The following is a description of a gene set: species: Homo sapiens Genes down-regulated in unstimulated macrophages: IL10 knockout versus NFKB1 knockout. Human Gene Set: GSE19941_IL10_KO_VS_IL10_KO_AND_NFKBP50_KO_UNSTIM_MACROPHAGE_DN Bone marrow-derived macrophages were produced from mice lacking IL-10 alone (IL10-def) or mice lacking both IL-10 and the p50/p105 subunit of NF-kB (p50/IL10), and left unstimulated, stimulated with LPS (1 ng/ml) or stimulated with LPS and IL-10 (0.3 ng/ml). from publication Yang HT, Wang Y, Zhao X, Demissie E, Papoutsopoulou S, Mambole A, O'Garra A, Tomczak MF, Erdman SE, Fox JG, Ley SC, Horwitz BH (PMID 21217011), and this is the list of marker genes: MAGED1, SARAF, TMEM176B, ERMN, EPHA2, ZNF451, ABCB10, CUBN, PTGFR, MED13L, EMP1 (epithelial membrane protein 1), SLCO2A1, PTPN3, CCNB3, HOXD10, WDFY4, DLEU7, IFFO2, FBXO6, EBF1, PGAM1, PIK3R5, PI4K2A, IL20RA, IGSF11, ADM, TSPAN13, SKIL, MTSS1, VPS39, ZDHHC18, PALS1, DNAAF4, TLE2, TMEM104, GKAP1, EOLA1, DCC, PLAC8, PLAUR, GAD1, KIF1A, N4BP1, IRAG1, GPR65 (G protein-coupled receptor 65), CRTC3, VWA5B2 (von Willebrand factor A domain containing 5B2), WWP1, GLI3, CYFIP2, ASPN, AKTIP, ATG4C, TENT2, LAMP2, PCED1B, AQP9, GOLGA4, TCP11L2, GLIS2, RORA, MCTP2, PIK3R1, NLRP3, DNAJC10, GOLM1, GPR15, MFSD2A, BCL2L2, MAP3K6, ELFN1, PLD3, PITPNC1, AVL9, ERBB4, KRT18, RALA, STX12, SNORD89, RAB3GAP2 (NCBI Gene Id 26114), LARGE1, LAPTM5, SMOX, ARHGAP45, TBCEL, DDRGK1, ICOS, ERCC5, IPMK, ZSCAN12, B9D1 (B9 domain containing 1), SWAP70, TOX2, TOLLIP, RECK, GADD45A, WDR24, PIWIL2, ATG4A, MFNG, ID2, FERMT3, FAM241A, ABI3, LRP4, RMC1, SGK1, MADD, NBEAL1, ARHGAP30, NGEF, NCOA1, SMURF1, FOSL2, ATXN1L, USP22, RNF6, MKX, NCS1, CTSD, KMT2D, VSIR, BET1L, LRP12, GEM, ARFGAP3, NGF, MYOF, SMAD4, COL13A1, RADIL, HOGA1, L1CAM, ST6GALNAC5, CYRIB, CYP11B2, FBXL16, F2, MBD3L1, RAMP1 (NCBI Gene Id 10267), RAC3, ZMYND11, SYTL4, KLF9, DPY19L3, TUBB2B, ABHD14A, KPNA7, DCTN4, TULP3, CNGA1, WNT2, NXNL2 (nucleoredoxin like 2), MSMB, LACTBL1, CYB5D2, ZC3H12A, CPD, LRP1, CCDC186, CABP4, RIN2, SH2B1 (NCBI Gene Id 25970), NPR1, GDF11, KCNMB4, JARID2, SH3PXD2B, UFM1, KCNG1, KRT20, COCH (NCBI Gene Id 23718), PACS2, ZNF804A, TBKBP1 (TBK1 binding protein 1), TBC1D20, BTBD7, LAMC2, CPEB4, CEBPD, PTGFRN, TMC5, TNFRSF1A, LONRF1, KDM3A, MACROH2A1, ETV6, KRT26, GJA1 (NCBI Gene Id 7953), HLX, SAA1, MICALL2, PIGZ, CACFD1, WDR37, FAM171A1, ZNF385A, RGL2, KLF6, YPEL5